The following is a description of a gene set: Any vesicle associated with the Golgi complex and involved in mediating transport within the Golgi or between the Golgi and other parts of the cell. species: Mus musculus Mouse Gene Set: GOCC_GOLGI_ASSOCIATED_VESICLE, and this is the list of marker genes: Lyz1, Cltb, Stk26, Itm2b, Rab27b, Acr, Gnas, Use1, Furin, Scfd1, Spg21 (SPG21, maspardin), Bnip1, Ap1s1, Copg1, Clrn1, Actr1a, Lrrk2, Cltc, Nrgn, Sppl2a, Dipk2a, Vps41, Nucb1, Kdelr2, Rab12, Ap1m1, Bet1l, Ap1b1, Scyl1 (NCBI Gene Id 98159), Cope, Tmed10, Rab14, Ap1s3, Cideb, Gopc, Tgoln1, Clba1, Steap2, Rab13, Chic2, Pi4ka, Adam10, Tmed2 (NCBI Gene Id 76322), Map6d1, Ccdc88a, Copz2, Sppl3, App, Rab8b, Copa, Gnrh1 (gonadotropin releasing hormone 1), Copg2 (coatomer protein complex, subunit gamma 2), Copz1, Golga5, Stk16, Bsn, Ap1s2, Rab8a, Slc2a4, Slc18a3, Sppl2c, Zdhhc13, Arcn1, Gpr89, Clta, Cspg5, Sec22b, Ccdc115, Atp7a, Ap4b1, Ap1g2, Map6, Dop1a, Igf2r, Ap1m2, Aftph, Tmem199, Unc13a, Arf1, Synrg, Rassf9, Copb2, Sort1, Lyz2, Tmed3, Cubn, Pclo, Kdelr1, Erc2, Kdelr3, Sppl2b, Pacs1, Pacsin1 (NCBI Gene Id 353072), Zdhhc17, Ap1g1 (NCBI Gene Id 52301), Smn1, Copb1